Given this list of marker genes CPEB1, FMR1, PARP16, UNK (unk zinc finger), NMNAT2, ALKBH3, CPEB2, CPEB3, CPEB4, RBM24, here is a description of the gene set: Any process that stops, prevents or reduces the frequency, rate or extent of cytoplasmic translation. species: Homo sapiens Human Gene Set: GOBP_NEGATIVE_REGULATION_OF_CYTOPLASMIC_TRANSLATION